The following is a description of a gene set: studied in species Homo sapiens An enzyme complex that catalyzes the transfer of GlcNAc from UDP-GlcNAc to an acceptor phosphatidylinositol, the first step in the production of GPI anchors for cell surface proteins. The complex contains PIG-A, PIG-C, PIG-H, PIG-Q, PIG-P, and DPM2 in human, and Eri1p, Gpi1p, Gpi2p, Gpi15p, Gpi19p, and Spt14p in budding yeast. Human Gene Set: GOCC_GLYCOSYLPHOSPHATIDYLINOSITOL_N_ACETYLGLUCOSAMINYLTRANSFERASE_GPI_GNT_COMPLEX, and this is the list of marker genes: PIGC, PIGP, PIGA, PIGH, PIGY, DPM2, PIGQ